The following is a description of a gene set: studied in species Homo sapiens Human Gene Set: GOBP_RESPONSE_TO_SELENIUM_ION Any process that results in a change in state or activity of a cell or an organism (in terms of movement, secretion, enzyme production, gene expression, etc.) as a result of a stimulus from selenium ion., and this is the list of marker genes: PTGS2, SELENOM, GPX1, SELENOV, HPGDS, ALAD, SELENOP, SOD2, SELENOW, TXNRD2, IL13